The following is a description of a gene set: Bony fusion of the mandibular condyle to the base of the skull, resulting in limitation of jaw opening. Human Gene Set: HP_TEMPOROMANDIBULAR_JOINT_ANKYLOSIS species: Homo sapiens Temporomandibular joint ankylosis, and this is the list of marker genes: SF3B4, ZMPSTE24, PLCB4, IDS, LMNA